Given this list of marker genes ACP5, ALDH18A1, MFN2, TONSL, MME, KRT5, NAGLU, COL9A2, COL9A3, KRT17, MAFB, HYAL1, MMP13, SPG7, COMP, LMX1B, KRT6B, MT-ATP6, BSCL2, TGFB1, KRT6A, HTRA1, LEMD3, RASA1, GJB6, COL2A1, COL11A1, COL9A1, ERLIN1, TRAPPC2, HEPHL1, PRKRA, MT-TK, SCO2, NLRP12, B2M, KRT16, MATN3 (matrilin 3), SLCO2A1, KRT14, GJB2, here is a description of the gene set: Human Gene Set: HP_LOWER_LIMB_PAIN Lower limb pain An unpleasant sensation characterized by physical discomfort (such as pricking, throbbing, or aching) localized to the leg. species: Homo sapiens